Given this list of marker genes IQSEC3, BDNF, AGO2, ARNT2, CREBBP, MAPK3, BMAL1, NPAS4, AGO3, FOS, MAGED1 (NCBI Gene Id 9500), TNRC6C, REST, NR3C1, MOV10, INS, NAMPT, CDK5, KCNIP3, AGO1, miR-224, TNRC6B, MDM2, SYT10, CDK5R1, PLK2, GEM, ARNT, XPO1 (exportin 1), SRF, TNRC6A, RET (NCBI Gene Id 5979), AGO4, RBFOX3, MAPK1 (mitogen-activated protein kinase 1), here is a description of the gene set: NPAS4 (Neuronal PAS domain containing protein 4) is a calcium dependent transcription factor predominantly expressed in neurons that regulates activation of genes involved in neuronal circuit formation, function, and plasticity. NPAS4 possesses a conserved basic helix loop helix (bHLH) motif and a PAS domain. NPAS4 is among the most rapidly induced immediate early genes (IEGs), which are activated after sensory and behavioral experience and thought to be crucial for formation of long term memory. NPAS4 is activated within minutes of neuronal stimulation to regulate the formation of inhibitory synapses. Transcriptional targets of NPAS4 include transcription factors and proteins involved in signal transduction and protein trafficking. NPAS4 regulates development of glutamatergic and GABAergic synapses essential for information processing and memory formation. NPAS4 induced gene expression programs differ between excitatory and inhibitory neurons, leading to a circuit wide homeostatic response. Besides directly regulating function of neurons, NPAS4 may be involved in the regulation of neuroinflammation and neuronal apoptosis. NPAS4 is expressed in the pancreatic beta cells and regulates their function under stress conditions. For review, please refer to Sun and Lin 2016, and Fu et al. 2020. part of: Generic Transcription Pathway studied in species Homo sapiens Reactome Pathway: Transcriptional Regulation by NPAS4